Given this list of marker genes GNG11, GNAI2, GNG7 (G protein subunit gamma 7), GNG4, GNG5 (G protein subunit gamma 5), GNB1, GNB3, GNAT3, GNGT1, GNG3, GNG13, GNB5, GNG2, GNAI3, GNG12, GNB4, GNG8, GNB2, GNGT2, GNG10, P2RY12, GNAI1, here is a description of the gene set: Reactome Pathway: ADP signalling through P2Y purinoceptor 12 part of: Signal amplification Co-activation of P2Y1 and P2Y12 is necessary for complete platelet activation. P2Y1 is coupled to Gq and helps trigger the release of calcium from internal stores, leading to weak and reversible platelet aggregation. P2Y12 is Gi coupled, inhibiting adenylate cyclase, leading to decreased cAMP, a consequent decrease in cAMP-dependent protein kinase activity which increases cytoplasmic, necessary for activation.<br> In activated platelets, P2Y12 signaling is required for the amplification of aggregation induced by all platelet agonists including collagen, thrombin, thromboxane, adrenaline and serotonin. P2Y12 activation causes potentiation of thromboxane generation, secretion leading to irreversible platelet aggregation and thrombus stabilization. species: Homo sapiens